Given this list of marker genes PLCB1, RELA, PLCD3, IKBKB, AKT3, IL12B, CHUK, PLCB3, PIK3CA, PIK3CB, ITPR1, TNF, IKBKG, PLCB4, PIK3CG, PLCE1, IL6, NFKBIA, PLCG1, PLCB2, CXCL8, IL12A, RETN, PLCG2, PIK3CD, PLCD4, MAPK1, AKT1, PLCD1, MAPK14, MAPK3, NFKB1, AKT2, here is a description of the gene set: Resistin as a regulator of inflammation studied in species Homo sapiens Human Gene Set: WP_RESISTIN_AS_A_REGULATOR_OF_INFLAMMATION